The following is a description of a gene set: Human Gene Set: MIR3620_3P from publication Chen Y, Wang X (PMID 31504780) Genes predicted to be targets of miRBase v22 microRNA hsa-miR-3620-3p in miRDB v6.0 with MirTarget v4 prediction scores > 80 (high confidence targets). studied in species Homo sapiens, and this is the list of marker genes: AMOT, NADK2, CAPRIN1, LARP1B, SZRD1, LILRA5, LINC03105, FAHD1, HOXA1, RASGRF1, NR2C2, HIC2, ZCCHC3, SYNGAP1, EPHA5, TENM2, DQX1, TTC1, USP46, ZNF502, HNRNPA1, SLC26A5, ST6GALNAC5, SRPK1, RORA, ENSG00000277067, BMF, FBXO30, GRSF1, CAMKK2, ZNF710, DOCK11, PTPRK, ATRNL1, TAFA2, PRLR, ZNF805, SEMA4F, KCNB1, POLR2D, ARK2C, ZNF454, NUAK1 (NUAK family kinase 1), DOCK3, SFRP1, FXYD3, NRBF2 (NCBI Gene Id 91155), BTG4, KCNS3, TMEM161B, LRP12, WDR26, PFN2, AMER1, LINC03104, BTN2A1 (butyrophilin subfamily 2 member A1), NCOA6, TMEM170B, FAM43B, HTR7, LVRN (NCBI Gene Id 206338), RAP2A, ACP3, FOXF2, LYRM2, NDUFA2, SYT13